The following is a description of a gene set: Class III of genes transiently induced by EGF in 184A1 cells (mammary epithelium). Human Gene Set: ZWANG_CLASS_3_TRANSIENTLY_INDUCED_BY_EGF Normal cells require continuous exposure to growth factors in order to cross a restriction point and commit to cell-cycle progression. This can be replaced by two short, appropriately spaced pulses of growth factors, where the first pulse primes a process, which is completed by the second pulse, and enables restriction point crossing. Through integration of comprehensive proteomic and transcriptomic analyses of each pulse, we identified three processes that regulate restriction point crossing: (1) The first pulse induces essential metabolic enzymes and activates p53-dependent restraining processes. (2) The second pulse eliminates, via the PI3K/AKT pathway, the suppressive action of p53, as well as (3) sets an ERK-EGR1 threshold mechanism, which digitizes graded external signals into an all-or-none decision obligatory for S phase entry. Together, our findings uncover two gating mechanisms, which ensure that cells ignore fortuitous growth factors and undergo proliferation only in response to consistent mitogenic signals. from publication Zwang Y, Sas-Chen A, Drier Y, Shay T, Avraham R, Lauriola M, Shema E, Lidor-Nili E, Jacob-Hirsch J, Amariglio N, Lu Y, Mills GB, Rechavi G, Oren M, Domany E, Yarden Y (PMID 21596316) species: Homo sapiens, and this is the list of marker genes: NFKB2, GATA6, NR4A1, ATF3, SEMA3A, KLF16, CSRNP1, DPP4, TRIB1, C3orf52, JAG1, RORA, PDP1, TXNRD1, F2RL1, NRG1, LMO7, SERTAD2, LRATD2, PPTC7, KLK6, FRMD6, RNU6-74P, APOBEC3B, MBP, PTP4A1, IRF2BPL, CHMP1B, MTF1, FAM83B, EDN1, DCUN1D3, RAP2B, PTGS2, RIPK4, RN7SL815P, ELF3, METRNL, PPP1R3B, BCL3, MIR106B, IPPK, SH3BP4, MACC1, ADM, GEM, RCAN1, NUMBL, B3GNT5, PPP1R15A, FOSL2, RUNX1, PER1, SLC22A13, BLZF1, KLF3, EPHA2, CCNL1, CAVIN2, HRH1, DUSP1, AFF1, DLC1, ARHGAP42, KLF4, ITPRIP, CEMIP2, SBNO2 (NCBI Gene Id 22904), NAP1L1, CSNK1E, CAMSAP1, KDM6B, MAFF, SOCS3 (NCBI Gene Id 9021), PPP1R14C, GSE1, RGS21, MYPN, RN7SL368P, MAP3K8, GALNT7, CXCL8, VMP1, CLDN1, ERVK-28, RBMS1, NR4A3 (NCBI Gene Id 8013), BIRC3, PLAC8, CCL20, KRT12, BTBD3, CRIP2, RND3, COBL, SYT12, MMP19, DMBT1, ITGA2, TACSTD2, RGS2, DUSP5, ANO6, NR4A2, PPFIBP1, FKBP5, VGLL3, VSNL1, FERMT2, CASP9, ZFP36L1, RN7SL600P, ADAMTS9, PLK2, OLR1, TIPARP, NFKBIZ, TFRC, IGF1R, VTRNA1-3, IL1B, MOSMO, PLPP3, STEAP4, RNU6-212P, FNDC3A, DUSP14 (dual specificity phosphatase 14), MAFK, ETS1, SGMS2, EIF2AK3, FOXA1, ZBTB38, SOWAHC, ZNF202, RASA2, PANX1, SLC2A1, JUNB, PSD3, PYGM, HBEGF, IL1RN, TJP1, CXCL2 (C-X-C motif chemokine ligand 2), IL6, WWC1, PELI1, RIMKLBP1, DNMBP, SIK1, LATS2, TGIF1, ZC3H12A, ARL5B, LINC00842, PFKFB3, SMAD7, FBXL2, TMEM67, SLC20A1, ZC3H12C, ASAP2 (ArfGAP with SH3 domain, ankyrin repeat and PH domain 2), STX11, NCL, MIR23AHG, SEMA3C, ZSWIM6, CCDC71L, ETS2, TJP2, GPCPD1, PURB, PROS1, DBP, TLE3, NCOA7, RN7SL472P, FRMD4B, CXCL1, ADGRF4, MTM1, TOB1, HOXA1 (homeobox A1), CLDND1, BHLHE40, RPUSD2, IER3, IFNE, RIMKLB, NFKB1, TNFAIP3, TP63, PLAUR, SLC20A2, SNRK, STK38L, UGCG, KIAA0040, SERPINE1, FOSB, ELL2, HES1 (hes family bHLH transcription factor 1), HIVEP2, IL1A, MCL1, CEBPD, OCLNP1, KLF13, NDRG1, GABPB1, IL1RAP, RNU6-767P, RAPGEF2, PHLDB2, CPEB2, EMP1, NCEH1, OTUD1, JOSD1, ATXN1, WEE1, MBNL2, MYADM, CD55, FOS (NCBI Gene Id 2353), RN7SL636P, NAB1 (NCBI Gene Id 4664), PER2, EZR, DENND3, CLDN4